The following is a description of a gene set: Human Gene Set: GOBP_MESENCHYME_DEVELOPMENT The process whose specific outcome is the progression of a mesenchymal tissue over time, from its formation to the mature structure. A mesenchymal tissue is made up of loosely packed stellate cells. species: Homo sapiens, and this is the list of marker genes: SFRP2, SEMA6C, SEMA6D (NCBI Gene Id 80031), SNAI1, SEMA4G, MCRIP1, AXIN2, SEMA4F, LOXL2, NRP2, TAPT1, BMP7, HEY1, EFNA1, MEOX1, HIF1A, RBM24, TBX3, IL17RD, FERMT2, RBPJ (recombination signal binding protein for immunoglobulin kappa J region), PAX2, ISL1, TGFB3, LIMS1, MDK, RET, LRG1, EDNRA, HNRNPAB, GSC, SEMA4D, OLFM1, SIX4, ELL3, MIR573, AMER1, WNT10A, MIR590, TGFBR1, ADAM8, MIR29B1, MIR145, BAMBI, SCX, RDH10, WNT2, SNAI2, ARB2A, TSPY1, RANBP3L, TSPY8, AGT, AMELX, NUP133, TCF7L2, JAG1, CDC42, SIX2, MIR149, DLL3, QKI, MIR222, FOXC1, TEAD2, WT1, GSK3B, MEF2C, BCL2, NKX2-1, EPB41L5, CDH2, ALDH1A2, ACVR1, PPP3R1 (NCBI Gene Id 5534), EDNRB, EPHA3, FOXH1, TBX5, S100A4, SEMA4B, MAD2L2, ROBO1 (NCBI Gene Id 6091), NCKAP1, BMPR2, MSX1, ACTG2, EOMES, LRP6, GREM1, SEMA3D, HAS2, COL1A1, POLR1B, HEYL, CUL7, FGF8, MIR379, NRTN, FBXL17, SFRP1, FBXO11, SMAD7, WNT16 (NCBI Gene Id 51384, Wnt family member 16), MIR19A, SP6, SEMA6B, PEF1, SPRED2, FGF9, NRG1, MIR302B (microRNA 302b), PDCD4, DAB2IP, CPLANE2, SOX9, SEMA3E, ZNF703, KDM1A, SEMA5A, LOXL3, SEMA7A, ROBO2, EXT1, CRELD1, YAP1, MIR130A, DPPA4, ERBB4, OTUD5, PRICKLE1, DKK1, FGFR1, DAND5, HDAC2, AMH, MIR144, AKNA, ZNF750, ADIPOR1, OVOL2, HTR2B, SMO, NRP1, PDPN, BMP5, GLIPR2, ENG, GATA5, TRIM28, PTK7, EDN1, KBTBD8, TGFBR2, NCLN, MARK1, SEMA6A (NCBI Gene Id 57556), FRZB, TCOF1, WNT4 (Wnt family member 4), NCAM1, MIR372, NEDD4, HES1, BMP2, LDLRAD4, SPRED3, DDX5, MIR221, IL1B, TSPY10, BMPR1A, NOMO1, TSPY2, SPRY1, MIR19B1, SMAD2, ACTA1, GDNF, POGLUT1, WNT5A, SEMA3B, FAM83D, NOG, VASN (vasorin), SEMA3F, BNC2, TIAM1, NOLC1, MIR202, TNXB (NCBI Gene Id 7148), ZEB2, ZFP64, PTEN, MAPK1, TWIST1 (NCBI Gene Id 7967), RTN4, EZH2, HPN, EPHA4, TSPY3, TGFB1, SPRED1, ACTC1, KAT8, ACVRL1, ZIC3, CYP26C1, EXOC4, TGFBR3, SLC39A6, TRIM62, WNT3A, USF3, SERPINB3, RFLNB, EDN3, PPP2CA, MIR326, WNT11, GBX2, DACT3, TBX20, LEF1, FN1, APLNR, EMP2, TBX1, PKD2, PTK2, HAND2, DLG5, PITX2, FUZ, VEGFA, SDHAF2, SDCBP, TGFB1I1, SPSB3, EFNB1 (NCBI Gene Id 1947), SMAD4 (NCBI Gene Id 4089), MESP1, MTOR, SEMA4C, OSR1, SPRY2, RPS7, RGCC, FGF19, STAT1, ROCK2, MIR342, KLHL12, SOX4, TASOR, GCNT2, MDM4, ACTA2, TGFB2, CITED2, FGFR2, PDCD6, ADAMTS5, HGF, NOTCH1, BMP4, WWTR1, FOXF2, BASP1, SOX10, ERBB3, MIR204, ZFPM2, FOLR1, DAB2, SEMA3C, NOTCH4, NODAL, HOXA5, TAF10, MIR519D, MIR21, LAMA5, CORO1C, NKX2-5, BCL9L, HAND1, SEMA4A, FOXD1, MYC, FOXC2, GATA4, FGF10, APC, CTNNB1, ADAM15, SOX8, SEMA3A, MSX2, FOXA1 (forkhead box A1), IGF1, NOMO3, CRB2, TCF15, TCF21, SHH, NOS3, DCHS1, DSG2, TSPY9, TBX2 (NCBI Gene Id 6909), HEY2, MAPK3, DDX17, GATA3, MIR18A, PHACTR4, ALX1, SIX1, KITLG, FOXF1, APLF (aprataxin and PNKP like factor), TGFBR3L, SEMA3G, SLC39A10, SMAD3, PHOX2B (paired like homeobox 2B), MIR142, MDM2, IL6, TMEM100, TSPY4, ROCK1, WNT8A, HMGA2, ZFP36L1 (NCBI Gene Id 677), RADIL, POFUT2, CFL1, SEMA5B, FOXA2